Given this list of marker genes Vdr, Amz2, 5430401F13Rik, Bnc1, Ccdc88a, Ube2i, Eif1ad8, Ubap1, Glo1-ps, Srsf1, Dnajc15, Pigb, Ighg1, Ntf3, 4930447F24Rik, Kpna2, Cib1, Mbtps2 (NCBI Gene Id 675926), Ech1, Tspan15, Slc2a3, C130036L24Rik, Ptk2b, Rfwd3, BC004004, Tjp2, Ywhag, Gzmm, here is a description of the gene set: studied in species Mus musculus Mouse Gene Set: GM14410_TARGET_GENES from publication Yevshin I, Sharipov R, Kolmykov S, Kondrakhin Y, Kolpakov F (PMID 30445619)